Given this list of marker genes Ist1, Robo2 (NCBI Gene Id 72126), Ep300, Vegfa, Ngf, Islr2, Dixdc1, Apoe, Sema5a, Plxnb3, Ndel1, Map3k13, Rpl4, Stk25, Dcx, Rnd2, Ntrk2, Pafah1b1, Nin, Cdkl5 (cyclin dependent kinase like 5), Eif4g2, Cdh4, Fn1, Limk1, Gdi1, Sema7a, Ilk, Trak1, Tiam2, Lpar3, Adcy10, Robo1, Map1b, Braf, Map2k2, Gsk3b, Plxnb1, Lrp1, Ntrk3, Cyfip1, Crabp2, Wnt3, Wnt3a, Trpv2, Tnfrsf12a, Shox2, Myo5b, Amigo1, Pou4f2 (NCBI Gene Id 18997), Stk11, Plxnd1, Mapt, Dbn1, Golga4, Zfyve27, Eif2b2, Chodl, Efna5, Plxnc1, Twf2, Picalm, Map6, Snap91 (NCBI Gene Id 20616), Tiam1, Disc1, Nrdc, Arhgap32, Skil (SKI-like), Bdnf, Srf, Adnp, Slitrk1, Rufy3, Ache, Trpc5, Ntn1, Zeb2, Nrp1, Dscam, Sema4d, Anapc2, Fxn, Golga2, Megf8, Bcl11a, Smurf1, Map2k1, Shtn1 (NCBI Gene Id 71653), Macf1, Nefl, Metrn, Plxnb2, L1cam, Dbnl, Pak1, Bmpr2, Cxcl12, here is a description of the gene set: studied in species Mus musculus Mouse Gene Set: GOBP_POSITIVE_REGULATION_OF_AXONOGENESIS Any process that activates or increases the frequency, rate or extent of axonogenesis.